Given this list of marker genes TMED2, ELL2, RBM4, SAMHD1, NPC1, IAPP, ESYT1, IFIT5, UNG, PPT1, METTL13, PRPF3, TOR1A, MOB1A, MYL12A, ARHGEF18, DNAJC9, CELA2A, GLB1, HARS2, MED12, KIFBP, PSMD9, MKNK1, DDX46, ZBTB7B, PRPS1L1, PTPN18, MAP2K6, SPTSSA, MLLT1, ACOX1, BCL6 (BCL6 transcription repressor), USP7, NME6, DIMT1, PRMT3, API5, VAMP4, LPP, HNRNPH2, SAMM50, QDPR, APOOL, CCR7, ZNF804A, TRAF1, LARP4B, TMED7, TRIM27, MCFD2, GTF3C1, ROR2, ZNF207, CA5B, PPBPP2, MAT2A, IL4, KLK3, NEFL, PCGF2, CPQ, UCP3, TPM1, SV2A, LMO2, CPSF4, PHF8, BRCA2, PHLDA2, CDKN3, INPP5A, TFE3, KRT10, ALDH1B1, UBR4, ENTPD4, CAMK1, GAB1, HLA-DOA, TGOLN2, H2BC7, VCP, KCNS1, GLS (NCBI Gene Id 51679), CCDC85B, PDGFA, MARCKSL1, RABEP1, SIAH1, HOXA11, BNIP1, ATP6V1G1 (NCBI Gene Id 9550), RIMS3, C4BPA, CIITA, AP1G1, PFKFB1, IKBKG (NCBI Gene Id 8517), ADAM15, REL, SPRR2C, CD83, PHB2, PRP4K, ATP2B3, CD1E, TSPAN6, SLA, MDH1, ITSN2, CELF2, MYO1E, SUPT7L, TUBB, DHRS2, RAP1A, SIPA1L3, DIAPH1, ZNF137P, PRMT1, SMNDC1, CACNB1, B4GALT3, KRT76, LINC01278, RSBN1, SF3A2, CD40, C6orf120, PXN, FOXF1, TAF10, ITPA (inosine triphosphatase), ZNF124, ZMYND8, BCR, EXPH5, AKR1C3, PAQR3, CDS1, ACLY, LMO1, ARL3, PRKAR1A, OPRM1, ENSA, STK4, TST, TNRC6B (NCBI Gene Id 23112), SP3, GREB1, EIF2S3, GNB5, ACRV1, IDH3A, LRRN2, MAN1A1, KIDINS220, FMNL1, MBNL2, TSPOAP1, TCTA, CTSL, UBE2L3, TUBA1A (tubulin alpha 1a), FHL1, PTPRB, COL19A1, IVD, ISG20L2, BAK1, BSN, SMC3, MISP, HLA-DPA1, HNRNPA3, DNAH7, SRGN, NPRL2, LORICRIN, MAPK9, GPX3, WSB2, ADCYAP1R1, WNT2B, SPINT1, ELAVL2, FNDC3A, ARFGEF1, STX10, LIG4, KHDRBS3, WDR37, AREL1, DDOST, PYGB, ATP11B, HLA-DQB1, CD38, here is a description of the gene set: Human Gene Set: GSE360_DC_VS_MAC_UP Monocyte-derived dendritic cells (DC) and macrophages (MΦ) generated in vitro from the same individual blood donors were exposed to five different pathogens, and gene expression profiles were assessed by microarray analysis. Responses to Mycobacterium tuberculosis and to phylogenetically distinct protozoan (Leishmania major, L. donovani, Toxoplasma gondii) and helminth (Brugia malayi) parasites were examined, each of which produces chronic infections in humans yet vary considerably in the nature of the immune responses they trigger. Genes up-regulated in comparison of dendritic cells (DC) versus untreated macrophages. species: Homo sapiens from publication Chaussabel D, Semnani RT, McDowell MA, Sacks D, Sher A, Nutman TB (PMID 12663451)